The following is a description of a gene set: Disseminated intravascular coagulation Human Gene Set: HP_DISSEMINATED_INTRAVASCULAR_COAGULATION species: Homo sapiens Disseminated intravascular coagulation is characterized by the widespread activation of coagulation, which results in the intravascular formation of fibrin and ultimately thrombotic occlusion of small and midsize vessels., and this is the list of marker genes: CD46, CFI, RARA, PROS1, NPM1, RYR1 (NCBI Gene Id 906), RASA1, IL6ST, FIP1L1, LIPA, MT-CO3, NABP1, TBL1XR1, PRKAR1A (protein kinase cAMP-dependent type I regulatory subunit alpha), OBSCN, IRF2BP2, SERPIND1, MT-CO1 (mitochondrially encoded cytochrome c oxidase I), BCOR, HELLPAR, LPIN1, STAT5B, PML, CFH (complement factor H), NUMA1, STAT3, NFS1, NLRC4, ZBTB16